Given this list of marker genes Nkg7 (NCBI Gene Id 72310), Jun, Gzma, Gzmc, Mecp2, Slamf7, Cxcr6, Pak1, Eomes, Pdcd1lg2, P2ry14, Gadd45b, Sema4a, E2f1, Rgs2, Fos, Havcr2, Ccnf, Dlk1, Cd244a, Ddx5, Ifng, Fasl, Pdcd1, here is a description of the gene set: from publication Ono M, Yaguchi H, Ohkura N, Kitabayashi I, Nagamura Y, Nomura T, Miyachi Y, Tsukada T, Sakaguchi S (PMID 17377532) Naturally arising CD25+CD4+ regulatory T cells (T(R) cells) are engaged in the maintenance of immunological self-tolerance and immune homeostasis by suppressing aberrant or excessive immune responses, such as autoimmune disease and allergy. T(R) cells specifically express the transcription factor Foxp3, a key regulator of T(R)-cell development and function. Ectopic expression of Foxp3 in conventional T cells is indeed sufficient to confer suppressive activity, repress the production of cytokines such as interleukin-2 (IL-2) and interferon-gamma (IFN-gamma), and upregulate T(R)-cell-associated molecules such as CD25, cytotoxic T-lymphocyte-associated antigen-4, and glucocorticoid-induced TNF-receptor-family-related protein. However, the method by which Foxp3 controls these molecular events has yet to be explained. Here we show that the transcription factor AML1 (acute myeloid leukaemia 1)/Runx1 (Runt-related transcription factor 1), which is crucially required for normal haematopoiesis including thymic T-cell development, activates IL-2 and IFN-gamma gene expression in conventional CD4+ T cells through binding to their respective promoters. In natural T(R) cells, Foxp3 interacts physically with AML1. Several lines of evidence support a model in which the interaction suppresses IL-2 and IFN-gamma production, upregulates T(R)-cell-associated molecules, and exerts suppressive activity. This transcriptional control of T(R)-cell function by an interaction between Foxp3 and AML1 can be exploited to control physiological and pathological T-cell-mediated immune responses. Mouse Gene Set: ONO_AML1_TARGETS_UP studied in species Mus musculus Genes up-regulated in CD4+ T lymphocytes by expression of AML1 off a viral vector.